Given this list of marker genes SEC62, H2AC13, APCS, HGF, GLUD1, MAB21L1, JUNB, SULT1C2, RASSF8, PIM2, MARCHF2, MNDA, ELOC, SEC22B, GSPT1, KCNS1, RPS23, ARID3A, TFAM, KRT85 (keratin 85), ODF1, ASF1A (NCBI Gene Id 25842), LINC00837, MAGOH (mago homolog, exon junction complex subunit), PDIA4, DHX8, CALCA, DACH1, LSM6, TP53TG1, ELF2, CIC, COX4I1, CD33, GRIN2B, OARD1, TRIP12, RPL37, TMEM30B, THBD, LAGE3, HSP90AA1, IFNA8, PTHLH, SLC35D2, H1-2, KCNJ13, PPARG, SLC5A5, TNNI3, IFI16, OPRM1, NGDN, PSMD10, ATP2C1, PNLIPRP1, AZIN1, SELL, KIF17, COL18A1, GGPS1, DZIP3, CCN6, AP3B2, PDS5B, EXTL1, SLCO2A1, H3-3B, BICD2, EFEMP2, BRINP1, ESM1, RUFY3, PLD3, CREG1, HOXA11, LIPC, MYL4, NR0B1 (NCBI Gene Id 8238), AP1G1, HNRNPM, TAF12, DCTD, GCSH, UBE2E1, CXCL2, LRPPRC (NCBI Gene Id 10303), F5, MUC7, ABCF2, ANO3, PYGL, ZNF143, CPA1, PLSCR1, SRSF1, METTL18 (methyltransferase 18, RPL3 N3(tau)-histidine), HDAC3, TADA3, CD163, PLPBP, CSNK1A1, PNN, MEN1, SLC22A2, BABAM2 (NCBI Gene Id 9577), SIGLEC7, ICAM1, PRPS1L1, RRS1, PDK4 (NCBI Gene Id 5166), AXIN1, LYPLA1, FOLR3, ETV1 (NCBI Gene Id 221810), EREG, CASR, TAF1B, SSPN, NCBP2, FABP5, STRAP (serine/threonine kinase receptor associated protein), PRDX1, DEPP1, SUPV3L1, PSMB8, SUPT7L, SRP54, CREBZF, AHSA1, AREG, HNRNPA2B1, RPP14, FBXL4, COBLL1, AGR2, NEFL, ELL2, WASF2 (NCBI Gene Id 10163), MAML1, LAPTM4A, UGT8, PPFIA2, SPTLC1, GTF2H2, ARPP19, HSPA4, KCNA1, ASGR2, PHOX2B, ERCC8, NDUFAF1, PLEKHB1, DEFA6, OXCT1, ISG15, G3BP1, POLR3F, MPPED2, ASGR1, TMPRSS11D, SRGAP2, NCLN, EIF1, IL6, MYRF, ACBD3, CCNC, TPD52L2 (NCBI Gene Id 7165), AIMP2, TMCO1, MAP3K9, MAP2K4, VDAC2, LGI1, ALDH3B1 (NCBI Gene Id 221), RPS28, S100A10, NCK1, SLITRK2, POLE3, KLF1, CYB561, TRPC2, RPL9, NPM1, CLIC2, KIF2A, LOXL2, MTAP, LCN2, BTF3P11 (basic transcription factor 3 pseudogene 11), IFIH1, LILRB4, HSD17B3, NDUFS1, KCNB1, PCDHGB7, here is a description of the gene set: Genes down-regulated in spleen dendritic cells: CD8- versus CD8+. To understand the functional relationship between brain dendritic cells (brain DCs) and other myeloid cells, we compared the gene expression profile of m/chDCs to that of bone marrow monocytes, brain microglia and classical spleen CD8+ and CD8- DCs. In order to obtain enough brain DCs for mRNA extraction, we expanded brain DCs with in vivo Flt3L treatment before purification. Human Gene Set: GSE29949_CD8_NEG_DC_SPLEEN_VS_CD8_POS_DC_SPLEEN_DN from publication Anandasabapathy N, Victora GD, Meredith M, Feder R, Dong B, Kluger C, Yao K, Dustin ML, Nussenzweig MC, Steinman RM, Liu K (PMID 21788405) species: Homo sapiens